The following is a description of a gene set: A tumor (abnormal growth of tissue) of the thymus. Human Gene Set: HP_NEOPLASM_OF_THE_THYMUS Neoplasm of the thymus species: Homo sapiens, and this is the list of marker genes: CDKN2C, CDKN1B, CDKN1A, AKT1, CDKN2B, MEN1